The following is a description of a gene set: studied in species Homo sapiens The process pertaining to the initial formation of an animal organ from unspecified parts. The process begins with the specific processes that contribute to the appearance of the discrete structure, such as inductive events, and ends when the structural rudiment of the organ is recognizable, such as a condensation of mesenchymal cells into the organ rudiment. Organs are a natural part or structure in an animal or a plant, capable of performing some special action (termed its function), which is essential to the life or well-being of the whole. The heart and lungs are organs of animals, and the petal and leaf are organs of plants. In animals the organs are generally made up of several tissues, one of which usually predominates, and determines the principal function of the organ. Human Gene Set: GOBP_ANIMAL_ORGAN_FORMATION, and this is the list of marker genes: RBM20, HOXA11, PIM1, FOLR1, MKS1, MAPK1, TGFBR2, GDNF, TBX5, WNT2B, MAP2K2, MESP1, HAND2, RBPJ, FGF10, BMP7 (NCBI Gene Id 655), TP63, NKX3-2, FGFR2, BMP4, AXIN2, FGF1 (NCBI Gene Id 29961), NTF4, SPRY1, GATA6, FRS2, PAX8, HES1, EXT1, BMP2, FOXH1, BMPR1A, HOXC11, MEF2C, ROBO1, MAP2K1, FGF8, SIX1, LEMD2, FGF2, TBR1, WNT5A, DKK1, GLI3, CTNNB1, SHH, WNT2, EMP2, ISL1, HOXA3, SULF1, SOX17, NOG, PAX2, AR, ROBO2, WNT11, POU5F1, RDH10, MAPK3, NOTCH1, LRP2, MIR20A, GATA5, WT1, SMARCD3, CITED2, EYA1, FGFR1